The following is a description of a gene set: part of: Translation of Structural Proteins Reactome Pathway: Maturation of protein 3a_9683673 Protein 3a is associated with protein M and is found in the virion, although its function in the structure seems non-essential. 3a is O-glycosylated and forms a homotetramer with porin function. studied in species Homo sapiens, and this is the list of marker genes: ST6GAL1, ST3GAL1, ST6GALNAC3, 3a, ST3GAL2, ST6GALNAC4, ST3GAL3, ST3GAL4, ST6GALNAC2, GALNT1